The following is a description of a gene set: Human Gene Set: GOBP_REGULATION_OF_MYOBLAST_FUSION Any process that modulates the frequency, rate or extent of myoblast fusion. species: Homo sapiens, and this is the list of marker genes: FLOT1, GDF15, SCGB3A1, RIPOR2, CAPN2, TNFSF14, CXCL9, MYOG, CD53, EHD2, EHD1, IL4R, CCL8, TMEM182, ADGRB1, CFLAR, NFATC2, PLEKHO1, MAPK14, MYOD1, CXCL10